The following is a description of a gene set: species: Mus musculus Any process that activates or increases the frequency, rate or extent of the chemical reactions and pathways involving isoprenoid. Mouse Gene Set: GOBP_POSITIVE_REGULATION_OF_ISOPRENOID_METABOLIC_PROCESS, and this is the list of marker genes: Rdh10 (NCBI Gene Id 98711), Rdh16, Rdh9, Rdh16f2, Rdh1, Rdh19